The following is a description of a gene set: Human Gene Set: GSE17974_0.5H_VS_72H_UNTREATED_IN_VITRO_CD4_TCELL_UP studied in species Homo sapiens Genes up-regulated in comparison of untreated CD4 T cells at 0.5 h versus the untreated cells at 72 h. The aim of this dataset was to study in detail the transcription kinetics initiated by cytokine IL-4 in early differentiation of Th2 cells. from publication Elo LL, Järvenpää H, Tuomela S, Raghav S, Ahlfors H, Laurila K, Gupta B, Lund RJ, Tahvanainen J, Hawkins RD, Oresic M, Lähdesmäki H, Rasool O, Rao KV, Aittokallio T, Lahesmaa R (PMID 20620947), and this is the list of marker genes: SRSF6, ERMN, SH3BP5-AS1, ZFP36, ZNF567, MTMR3, BCOR, SRGN, NFKBID, KBTBD2, POLR1C, VCPKMT, EGR3, ELOA, FCMR, TSPYL2, ZBTB49, ZHX1, PBXIP1, IQSEC1, CRAMP1, JOSD1, RRP15, MYH11, BTG2, QTRT2, TFIP11, ADNP2, RYK, GORAB, TBRG1, KLF11, SYNJ2BP, ATP2B1-AS1, SERINC5, CCNY, GABBR1, TPP2, YPEL5, KDM6A, L3MBTL3, TNFSF8, DGKE, ARHGAP21 (Rho GTPase activating protein 21), UTP15, ATG2A, S1PR1, NOL9, SOX6, SPTY2D1, TADA2B, FRAT1, SERPINA9, AKT2 (NCBI Gene Id 208), LEF1-AS1 (NCBI Gene Id 641518), ACTR5, MAN2B2, IKZF5, TMEM183A, CHD1, PIWIL4, SCML1, DANCR (NCBI Gene Id 57291), PPP6R2, DDX19B, SIK1, EFHC1, RNF139, FAM200B (NCBI Gene Id 285550), JMY, TRPM7, TMEM138, ID2, AKAP1, RBSN, LMTK2, PSME4, TMEM68, RBM19, SYNM, POLR1F, DNAJC25, GADD45B, CDC37L1, ZNF571, CENATAC, ZNF14, ARIH2, SNORA28, PPM1A, ZNF674-AS1, ZNF791, ZNF326, CXCL16 (NCBI Gene Id 58191), VPS18, GPCPD1, SLCO3A1, LINC01138, LAPTM4A, SEMA4C, DDX21, ATG14, RNF157-AS1 (RNF157 antisense RNA 1), GP6, TBL1X, AREG, ENSG00000274253, SORBS3, ZBTB10, CYP20A1, TSPYL1, BTBD9, RC3H1 (NCBI Gene Id 149041), NSMCE3, TXNDC11, C6orf58, DNLZ, ZXDA, NCOA5, TSC1, CSPG4P5, MORC2-AS1, SLC11A2, PMS2P9, TTC17, DDX52, PARGP1, SPATA2, MFSD14A, DNAJB9, GCFC2, ZXDB, PXN, SF3A1, ALG13, EIF5, CTU2, IFNGR1, TCTA, SFPQ, COQ10A, CYTH1, TAF1C, EGR2, CAST, ZXDC, ATXN1L, YKT6, ZNF10, CD83, NPIPB3, LEPROTL1, DYNLL2, NOL6, EDN1, SLC22A23, DAZAP2, C6orf226, RSRP1, SF1, FAM222B, TIMM23, KANSL2, TENT5A, CLUH, KLF2, DCAF16, DYRK2, SLC25A32, IGFBP7-AS1, IL1B, NAGPA, ZNF805, PLEKHM1, SLC25A33, BACH1, TRIB2, ITGA6, SIRT7, RNF220, SUCO, PTGER4, FAM204A (NCBI Gene Id 63877), PDZD8, NUFIP1, ANXA1, BEX2, RPS6KB1, MIR22HG, LTV1, FRS2, C1orf52, IRS2, PIK3R5